Given this list of marker genes Irf7, Cd300a, Ccdc134, Irf1, Cd300lf, here is a description of the gene set: Any process that modulates the frequency, rate, or extent of MyD88-dependent toll-like receptor signaling pathway. Mouse Gene Set: GOBP_REGULATION_OF_MYD88_DEPENDENT_TOLL_LIKE_RECEPTOR_SIGNALING_PATHWAY studied in species Mus musculus